The following is a description of a gene set: Signaling by MST1 Mouse Gene Set: REACTOME_SIGNALING_BY_MST1 species: Mus musculus, and this is the list of marker genes: Spint1, Mst1r, Hpn, Spint2, Mst1